The following is a description of a gene set: species: Mus musculus Mouse Gene Set: CUI_MIGDC_OSM_RESPONSE_DN from publication Cui A, Huang T, Li S, Ma A, Pérez JL, Sander C, Keskin DB, Wu CJ, Fraenkel E, Hacohen N (PMID 38057668) Cytokines mediate cell-cell communication in the immune system and represent important therapeutic targets. A myriad of studies have highlighted their central role in immune function, yet we lack a global view of the cellular responses of each immune cell type to each cytokine. To address this gap, the authors created the Immune Dictionary, a compendium of single-cell transcriptomic profiles of more than 17 immune cell types in response to each of 86 cytokines (>1,400 cytokine-cell type combinations) in mouse lymph nodes in vivo. A cytokine-centric view of the dictionary revealed that most cytokines induce highly cell-type-specific responses. For example, the inflammatory cytokine interleukin-1β induces distinct gene programmes in almost every cell type. A cell-type-centric view of the dictionary identified more than 66 cytokine-driven cellular polarization states across immune cell types, including previously uncharacterized states such as an interleukin-18-induced polyfunctional natural killer cell state. Genes negatively differentially expressed in cell type: MigDC (migratory dendritic cell) upon treatment with cytokine: OSM in mouse lymph nodes in vivo., and this is the list of marker genes: Apol7c, Hspa1a, Marcks (myristoylated alanine rich protein kinase C substrate), Rgs1, Hspa1b